The following is a description of a gene set: species: Mus musculus The Y-shaped region of a replicating DNA molecule, resulting from the separation of the DNA strands and in which the synthesis of new strands takes place. Also includes associated protein complexes. Mouse Gene Set: GOCC_REPLICATION_FORK, and this is the list of marker genes: Zmiz2, Mcm10, Rad51c, Tonsl, Baz1b, Rpa3, Trp53bp1, Helb, Rfc5, Bcas2, Cdc5l (NCBI Gene Id 71702), Timeless, Mus81, Pola1, Chek1, Eme1, Carm1, Cdc5lrt6, Cdc5lrt4, Primpol, Recql5, Dmap1, Ercc5 (excision repair cross-complementing rodent repair deficiency, complementation group 5), Cdc5lrt8, Cdc5lrt1, Etaa1, Polh, Hdac2, Rfc4, Prim1, Xpa, Trex1, Uhrf1, Cdc5lrt7, Donson, Xrcc3, Smarca5, E2f6, Pold2, Cdc5lrt5, Rfc2, Brip1 (NCBI Gene Id 73108), Pold3, Ube2b, Rpa2, Dnmt1, Trp53, Pold1, Eme2, Wdhd1, Cdc5lrt10, Mms22l, Hmces, Prim2, Blm, Radx, Rad18, Rpa1, Xrcc2, Plrg1, Rfc1, Smarcal1, Mre11a, Cdc5lrt9, Rfc3, Prpf19, Bcl6, Rad51b, Rad51d, H2ax, Pola2, Rtf2, Parp1, Nbn, Tipin, Smarcad1, Zranb3, Pold4, Tex264, Wrn, Pcna